Given this list of marker genes DCAF17, PLA2G6, MAP1LC3A, COASY, BECN1, MLST8, ATP13A2, CP, MECP2, ATG5, PANK2, TSC1, MTOR, ATG7, ATG14, DEPTOR, C19orf12, RPTOR, ACACA, WIPI2, ATG101, ATG13 (autophagy related 13), PIK3R4, SCP2, PRKAA1, ATG16L1, FTL, WIPI1, ATG3 (autophagy related 3), WDR45, STK11, RHEB, ATG10, ATG4A, RB1CC1, SPTLC1, ULK1, GTPBP2, FA2H, AKT1S1, ATG2A, TSC2, ATG12, PIK3C3, here is a description of the gene set: studied in species Homo sapiens Human Gene Set: WP_NEURODEGENERATION_WITH_BRAIN_IRON_ACCUMULATION_NBIA_SUBTYPES_PATHWAY Neurodegeneration with brain iron accumulation (NBIA) subtypes pathway